The following is a description of a gene set: species: Mus musculus from publication Chen Y, Wang X (PMID 31504780) Genes predicted to be targets of miRBase v22 microRNA mmu_miR_344f_5p in miRDB v6.0 with MirTarget v4 prediction scores > 80 (high confidence targets). Mouse Gene Set: MIR_344F_5P, and this is the list of marker genes: Gata6, Gtpbp1, Slc37a3 (solute carrier family 37 (glycerol-3-phosphate transporter), member 3), Siah1a, Ptbp2, Sash3, Zbtb18, Hectd4, Piwil1, Gpr155, Fign, Mbnl1, Kcnma1, Wwp1, Cpeb3, Kcnj10, Ptprcap, C2cd4a, Slc39a8, Tent4b, Edn2, Prdm1, Ripor2, Ppfia1, Col6a4, Gpr50, Scn3a, Hmgcs1, Steap2, Itsn1, Lsm14b, Aass, Ptgs2, Ddit4, Cox11 (NCBI Gene Id 69802), Pard6b, Ercc3, Lrat (NCBI Gene Id 99631), Klhl42, Dppa2, Crtam, Entpd3, Mycbp, Fbxw7, Nppc, Hypk, Ube2q1, Selenot, Slc43a2, Clec2m, Rubcnl, Adamts20, Syn1, Sh3bgrl2, Ebf3, Fubp3 (NCBI Gene Id 99249), Slc6a20b, Igf1r, Lysmd3, Mmp16, Atp7a (NCBI Gene Id 51824), Gm57852, Ptprh, Pdcl, Inpp4a, Fam13c, Krtap21-1, Usp40